The following is a description of a gene set: Human Gene Set: GAUCHER_PBMC_YF_VAX_STAMARIL_UNKNOWN_AGE_28DY_UP Correlates of immune-mediated protection to most viral and cancer vaccines are still unknown. This impedes the development of novel vaccines to incurable diseases such as HIV and cancer. In this study, we have used functional genomics and polychromatic flow cytometry to define the signature of the immune response to the yellow fever (YF) vaccine 17D (YF17D) in a cohort of 40 volunteers followed for up to 1 yr after vaccination. We show that immunization with YF17D leads to an integrated immune response that includes several effector arms of innate immunity, including complement, the inflammasome, and interferons, as well as adaptive immunity as shown by an early T cell response followed by a brisk and variable B cell response. Development of these responses is preceded, as demonstrated in three independent vaccination trials and in a novel in vitro system of primary immune responses (modular immune in vitro construct system), by the coordinated up-regulation of transcripts for specific transcription factors, including STAT1, IRF7, and ETS2, which are upstream of the different effector arms of the immune response. These results clearly show that the immune response to a strong vaccine is preceded by coordinated induction of master transcription factors that lead to the development of a broad, polyfunctional, and persistent immune response that integrates all effector cells of the immune system. studied in species Homo sapiens from publication Gaucher D, Therrien R, Kettaf N, Angermann BR, Boucher G, Filali-Mouhim A, Moser JM, Mehta RS, Drake DR 3rd, Castro E, Akondy R, Rinfret A, Yassine-Diab B, Said EA, Chouikh Y, Cameron MJ, Clum R, Kelvin D, Somogyi R, Greller LD, Balderas RS, Wilkinson P, Pantaleo G, Tartaglia J, Haddad EK, Sékaly RP (PMID 19047440) Genes up-regulated in peripheral blood mononuclear cell 28d vs 0d in unknown after exposure to YF-Vax/Stamaril, time point 28D, and this is the list of marker genes: RNF135, NAGA, PRAM1, OGFR, AP5B1, RNF31, MYO1F, MX1, FCER1G, SHISA5, MYD88, P2RX1, LY6E, TMEM121B, EPSTI1, CSRNP1, SIL1, RIPK3, HK3, IL1RN, ANPEP, SIGLEC5, LGALS9, ASPRV1, IRF9, NTNG2, OASL